Given this list of marker genes ACTR3, CFL1, PLD4, PTK2, CRK, IGHV1-46, LIMK1, DOCK1 (NCBI Gene Id 1793), IGKV5-2, FGR, IGLV1-44, IGKV1D-16, IGKV1-17, MAPK3, IGLV1-47, SRC, IGHG4, ARPC1A, WASL, CDC42, NF2, ARPC5, WIPF1, ARPC1B, IGKV1D-33, NCKAP1L, IGKV4-1, IGKV3-11, ACTR2, HSP90AA1, IGKV3-15, ARPC4 (NCBI Gene Id 10093), IGHV3-11, VAV1, SYK, YES1, PLD3, IGHV3-53, FYN, IGKV3D-20, ARPC2, IGHV4-59 (immunoglobulin heavy variable 4-59), PIK3CA, IGHV1-69 (immunoglobulin heavy variable 1-69), PIK3R2 (NCBI Gene Id 5296), IGKV2-28, IGHV1-2, HCK, MYO5A, IGLV3-1, MYO9B, ABI1, HSP90AB1 (heat shock protein 90 alpha family class B member 1), IGKV1-5, WASF1 (WASP family member 1), VAV2, PRKCD, LYN, IGLV6-57, IGLV2-14, IGHV2-5, ELMO2, MAPK1, IGHG2, IGHV3-13, WIPF3, NCKAP1, IGKV1-39, ACTB, IGKV1-16, CD3G, FCGR1A, IGLV7-43, PLA2G6, PLPP4, IGHV4-39, PAK1, IGLV1-40, CD247, IGHG1, NCK1, IGKV2D-28 (NCBI Gene Id 28883), IGLC2, VAV3 (NCBI Gene Id 10451), IGHV4-34, ELMO1 (engulfment and cell motility 1), MYH9, BAIAP2, WASF3, IGHV3-48, IGLV3-27, RAC1, IGKV1-33, IGHV3-23, IGLV1-51, ARPC3 (NCBI Gene Id 10094), IGLC3, PLD2, PLCG1, IGKV2D-40, WASF2, IGKV2-30, IGHV2-70, MYO1C, GRB2, PRKCE, WAS, ABI2, ACTG1, BTK, FCGR3A, PIK3R1, MYH2, FCGR2A, IGKV1-12, IGKV3-20, PLCG2, BRK1, IGLV3-25, PLD1, MYO10, ITPR3 (inositol 1,4,5-trisphosphate receptor type 3), IGKV2D-30, PLPP5, CYFIP1, IGHV3-33, ITPR1, IGKV1D-39, WIPF2, IGHV3-30, IGLV2-8, IGKV1D-12, IGHV3-7, CYFIP2, IGLV3-21, AHCYL1, IGLV3-19, PIK3CB, ABL1, IGLV2-11, ITPR2, IGLV2-23, NCKIPSD, here is a description of the gene set: Fcgamma receptor (FCGR) dependent phagocytosis species: Homo sapiens Human Gene Set: REACTOME_FCGAMMA_RECEPTOR_FCGR_DEPENDENT_PHAGOCYTOSIS